Given this list of marker genes FBXO31, ETS1, FBXO5, DMRT1, MSH2, MAPK12, NSUN2, TFDP3, DONSON, FOXC1, RBL1, TRIM37, BLM, MIR892B, DOT1L, TPRA1, MOS, BRIP1, XPC, CLOCK, BARD1, TIPRL, DTL, CDC6, ACVR1, TGFB1 (transforming growth factor beta 1), PPP1R13B, MIIP, KNL1, TPR, CHMP4C (NCBI Gene Id 92421), MIR195, BABAM1 (BRISC and BRCA1 A complex member 1), ATRX, RAD1, PPP1R10, PRKDC, HINFP, INCA1 (inhibitor of CDK, cyclin A1 interacting protein 1), RBM14, NUBP1, YTHDC2, STK38, MAD2L1, CDCA8, CCNB1, TP53I13, MIR29B1, HECA, TEX14, HEXIM2, PML, GFI1B, MYO16, TENT5B, STK35 (serine/threonine kinase 35), FBXO6, CUL4A, CDK2, NANOS2, HUS1, TTI2, NPPC, SDE2, TREX1, BRD4, PDIK1L, MIR873, RBL2, SIPA1, WAPL, CAMSAP3, MRE11, CDC45, LILRB1, TICRR (NCBI Gene Id 90381), CHEK2, CTDSP1, AVEN, MIR193A, NOP53, MTBP, MIR15A, PINX1, CDK5RAP3, E2F1, VPS4A, ESPL1, SPC24, MIR451A, LATS2, PTEN, CREB3, MBTPS2, HPGD, ATM, BMP4, MIR30C2, CHMP2A, GATA3, CHEK1, TAOK3, NHERF1, GNB1L, CDKN1A, KNTC1, RPA2, TAOK1, TAOK2, MBTPS1, SIRT1, HLA-G, POC5, RAD21, MIR29A, TOM1L1 (target of myb1 like 1 membrane trafficking protein), RPS6KA2, ORC1, MEN1, BRINP2, WAC, MIR21, CDK5RAP1, ZW10, CCL2, FAM107A, USP44, EME2, HTRA2, CCND1, EME1, RAD17, BCL2, INTS3, BTN2A2, TP53BP2, NEK11, DCUN1D3, ZWINT, TNKS, INHBA, KLF4 (NCBI Gene Id 9314), MIR19B1, MIR134 (NCBI Gene Id 406924), PRAP1, EZH2, PSMG2, LIF, FZR1, PKD2, CASP3, GPNMB, SCRIB (scribble planar cell polarity protein), GPR15LG, RAD9B, GTPBP4, ABRAXAS1, BRINP3, RPS27L, BRCC3, SUSD2, MIR26A1, SYF2, HASPIN, RRP8, RUNX3, BRCA2, MAPK14, FOXN3, PRP4K, CACNB4, IK, ATF5, IPO7, ZFP36L2, CDKN1C, MDM1, INTS7, IL10, GEN1, MIR29C, RB1, PTPN11, CLSPN, TOPBP1, INIP, DNA2, MIR133B, PRPF19, ANAPC15, MCIDAS, E2F7, CTDSP2, FZD3, APC, THAP5 (NCBI Gene Id 168451), TSC22D2, DYNC1LI1, H2AX, RNASEH2B, BCL6, SETMAR, TAF6, PROX1 (prospero homeobox 1), CDC73, PPP2R5B, RHNO1, GIGYF2, FHL1 (four and a half LIM domains 1), KLHL22, WDR76, BMP2, PABIR1, NME6, NAA10, MIR16-1, EIF2AK4, ZC3H12D, CDK2AP2, MIR424, SPC25, RAD9A (RAD9 checkpoint clamp component A), DAB2IP, PLK1, BRSK1, MIR15B (microRNA 15b), APBB1, SUV39H1, CDK5, CENATAC, TSPYL2, UIMC1, LCMT1, ZFP36L1, TP53BP1, NAE1, JADE1, MIR362 (NCBI Gene Id 574030), FBXO7, NBN, TRIM39, MUC1, SMARCA5, CEP63, WEE1, NEK2, RNF167, MRNIP, NABP1, NPR2, HUS1B, CTNNB1, FEM1B, ETAA1, ADCYAP1, PARP9, STK33, IPO5, TIPIN, BRD7 (bromodomain containing 7), FBXO4, ZFYVE19, RINT1, DUSP1 (NCBI Gene Id 1843), OVOL1, CDK5RAP2, PTPN3, SPDL1, DUX4, MACROH2A1, ZNF655 (zinc finger protein 655), TIMELESS, ALOX15B, FOXO4, PRMT2, RPA4, USP28, ZNHIT1, SKA3, BMP7, MIR638, TRIP13, DGKZ, APBB2, CENPF, ATR, ZNRF4, CDC5L, BUB1B, INHA, KANK2, BABAM2, MIR10A, E2F8, CTDSPL, CRY1, RBM46, ATRIP, SLFN11, NUF2, NDC80, CCAR2, TELO2, CDKN2B, RFPL1, EPM2A, NLRP2B, NPM1, LATS1, CDKN1B, CHFR, MAP3K20, PKMYT1, AURKAIP1, BUB3, SKA1, KAT2A, HORMAD1 (NCBI Gene Id 84072), ABL1, TRIM35, MIR503, RBBP8, CDKN2D (NCBI Gene Id 1032, cyclin dependent kinase inhibitor 2D), RHOB, TP53, PLK3, CDC14B, MIR137, ZNF830, RAD50, MAD2L1BP, MAD1L1, CDK1, ZWILCH, CEBPA, BRCA1, BUB1, NLE1, GAS1, GMNC, CRLF3 (NCBI Gene Id 51379), NABP2, MEIOC (meiosis specific with coiled-coil domain), INCENP, FANCD2 (NCBI Gene Id 2177), HOXC9, IER3, ERCC6, NUPR2, DTX3L, MIR133A1, BTG3, TRIAP1, BRINP1, GPER1, CDK6, DLG1, RAD51, MUS81, KIF25, GPR132, TFAP4, NUDT6, FBXO43, BIRC5, NUPR1, ANGEL2, ZBTB17, TMSB4X, BAZ1B, SOX2, RFWD3, XRCC3, RGCC, TNF, GMNN, PTPRK, ZNF207, ATF2, TOM1L2, CDKN2A, NR4A1, HOXD10, DACT1, TTI1, TTK, TMEM67, CDC20, AURKB, MAD2L2, UFL1, TERF2, KAT2B, MDC1, LYN, TERF1, CDT1, CCNF, here is a description of the gene set: studied in species Homo sapiens Human Gene Set: GOBP_NEGATIVE_REGULATION_OF_CELL_CYCLE Any process that stops, prevents or reduces the rate or extent of progression through the cell cycle.